Given this list of marker genes PGM2L1, SMC5, BBS12, TSR2, CHD5, CHST14, RPS28, LRP2, TP63, VPS13B, CLTC, NXN, MAPKAPK5, YWHAE, SALL4, TRPM3, TTC8 (tetratricopeptide repeat domain 8), BMP1, OCRL, WNT5A, ZBTB20, SCARF2, PGAP1, MGAT2, MYMX, EDEM3, EXTL3, TLK2 (NCBI Gene Id 11011), DHCR24, ADNP, DCHS1, KIF15 (kinesin family member 15), COPB2 (NCBI Gene Id 9276), MYMK, KRAS, TBR1, DBR1, SMARCA2, DVL3, TENM3, LRP4, PEX1, HHAT, DDR2, AGO1, COL11A2, BCORL1, CTBP1, CHRNG, PCDHGC4, NOTCH2, FANCF, SCN4A, C12orf57, PTEN, TBC1D2B, SNORD115-1, BCOR, AUTS2, ASPM, FANCG, BRCA1, DLG3, ZMYND11, BCL11B, SPECC1L, HS6ST2, CEP135 (centrosomal protein 135), KDM5A, AP3B2, ATP6V0A2, CLIP2, MKS1, SATB1, NTRK2, PEX13, EFEMP1, SCN1A, MCPH1, NSD1, CEP19, MAP2K2, TRIP12, PTCH1, OFD1, NBN, ASXL1, CHN1, RDH11, FOXP2, WDR35, LMNB1, UQCC2, INTS1, RBPJ, GPC6, RAI1, RAD51, KIF14, THOC6, KAT6B, SON, ACBD6, GPC3, PHOX2B, PDGFRB, SNAP29, KNL1, ITPR1, GPC4, KMT2A, RAB18, DMXL2, GATA4, PIGL, CRKL, PIGN, BBS7, POLR1C, PPP1R15B, MTOR, HSPG2, MSL3, BICRA, KAT5, KDM4B, RTL1, MASP1, POLR3A, TRIM32, MED12L (NCBI Gene Id 57726), PTPN11, SYNJ1, TBL2, DYNC1I2, SNX14, CERT1, COMT, NSD2, LMX1B, PWRN1, EED, NPHP1, KAT8, TUBGCP2, ZIC2, FBXO28, TMEM147, AFF3, HRAS, CHST3, MED12, FOXG1, GABRA3, RAPSN, UGDH, EZH2, WDR62, CASK, PIGT, ATP6V1B2, PIGW, ERMARD, PIGY, SEMA5A, PGAP2, FANCD2, FIBP, GABBR2, CEP295, ZNF292, CWC27, KCNB1, BUB1B, MYOD1, ATP1A2, RNU4-2, PRPS1, KCNC2, KREMEN1, FANCA, GNPNAT1, DGCR6, KCTD1, TBL1XR1, HNRNPR, SPOP, GABRG2, FBXO31, MEGF8, MVK (mevalonate kinase), PEX26, PITX1, CENPE, CDK19, SCLT1, CUX1, ORC1, EIF4H (eukaryotic translation initiation factor 4H), CLTCL1, BUD23, CHD1, WBP4, CAMTA1, ZMYM2, TAF1, KCNJ2, RNF2, HUWE1, CASP2, SMPD4, MOGS, SPEN, LIMK1, CRTAP, DPYSL5, NFIB, BRD4, FBN1, XRCC2, PRDM13, NAA60, H4C9, SLC19A3, KMT2C, RIT1, CEP57, HNRNPC, TRAK1, NR2F1, CCDC32, WASF1 (NCBI Gene Id 8936), SLC38A3, BBS5, CEP63, BCR, CIT, IRX5, UBE2T, STIL, KDM6A, LIG4, SLX4, DNA2, BAZ1B, TRRAP (transformation/transcription domain associated protein, NCBI Gene Id 8295), TBCK, SMO, ZSWIM6, GABRA5, MECP2, RNF135, BLTP1, SLC9A7, FOXP1, PUM1, TNRC6B, ESCO2, AMPD2, CHAMP1, SPIN4, PRR12, EXOC2, NUAK2, FBXL4, DNM1, TCOF1, CNOT2, PCGF2, ANKRD17, TWIST1, CUL4B, YY1, IL6ST, DONSON, LMNA, COL5A1, PIEZO2, PRMT7, RFC2, GMNN, UBR1, ACSL4, MAGEL2, MFSD2A, AP4E1, DYRK1A, TBCD, SPART, AP1S1, DVL1, CBL, ROR2, LTBP1, RECQL4, PGAP3, MUSK, PEX7, FGF12, TWIST2, SMC1A, NOTCH3, LDHD, QRICH1, RRAS, SETD2, CDH11, B3GAT3, NDN, CELF2 (CUGBP Elav-like family member 2), OTUD5, SASS6, MAP2K1, KDM1A, MTSS2, BRPF1, SIM1, DGCR2, ALDH6A1, DHODH, WDR26, SETD1B, DACT1, NFIA, ATP1A3, PIGA (NCBI Gene Id 5277), ARID1B (NCBI Gene Id 645070), MN1, NUP85, CACNA1A, COG1, DHX30, PAFAH1B1, CHD8 (chromodomain helicase DNA binding protein 8), FGFR2, RREB1, KIF11, NUS1 (NCBI Gene Id 116150), HERC1, EIF5A (eukaryotic translation initiation factor 5A), RBMX, GLE1, ARID2, TBX6, CD96, ATP7A, NALCN, PPP1R21, RBBP8, SLC26A2, TRMT10A, TMEM270, SLC1A2, OCA2, SLC39A13, PWAR1, ZFX, GP1BB, TRAPPC14, EBP, ASXL3, VAC14 (NCBI Gene Id 55697), LIFR, SPRED1, STAG2, DPH5, SKIC3, FHL1, UBE2A, MED13, GALNT2, CDK5RAP2, SHOC2, PYCR1, CNKSR2, RAF1, CTCF (CCCTC-binding factor), EFNB1, DEAF1, MYT1L (myelin transcription factor 1 like), KIF26A, KCNE5, NRAS, HIVEP2, PEX14, SUPT16H (NCBI Gene Id 6831), POLR1D, ANK1, RIN2, TFAP2B, DLK1, ANKLE2, POLR1A, PIGV, AGO2, PGM3, MCTP2, AMMECR1 (NCBI Gene Id 9949), HERC2, DALRD3, EXOSC2, SEPTIN9, TNNI2, HECTD4, APC2, MAPK1, CPLX1, ABCA5, RASA2, BBS4, EIF2AK3, RYR1, RBM10, PRKAR1B, FGF3, LZTR1, ERI1, BRIP1, BBS2, SKI, FKBP6, AFF4, ZMPSTE24, NCF1, KCNN3, AKT1, IDH1, DOCK3, DDB1, VPS35L, TOR1A, PPP3CA, TGFBR1, FAT4, LARP7, CDC42, BMPR1A, PIK3CA, FTSJ1, SEC24D, TGFB3, MAN1B1, FANCL, UBR7, H4C11, ELN, MAD2L2, SCN8A, FBXO11, TUBB, ORC6, SETBP1, SET (SET nuclear proto-oncogene), PEX12, FANCM, MAFB (MAF bZIP transcription factor B), ADAMTS2, FLCN, STAC3, GPKOW (G-patch domain and KOW motifs), CRELD1, PMM2, WDPCP, MAPK8IP3, NECTIN1, NONO, PEX19 (NCBI Gene Id 7835), RFX7 (NCBI Gene Id 64864), SYNGAP1, POGZ, HNRNPK, MAP3K7, IFT56, PDE4D, SEC24C, CNTNAP2, FIG4, GAD1, TCF4, BRAF (B-Raf proto-oncogene, serine/threonine kinase), CLP1, NAA20, RIPK4, FGD1, ADAMTS3, LETM1, SOS2, BPTF, SCNM1, TBX15, DLX4, TRAPPC10, SLC30A9, TAF13, HDAC4, SLC29A3, SUZ12, PEX6, KIF7, TUBB3, RTTN, HEATR3, PACS1, SATB2, MYCN, DNMT3A, ERCC6, SETD1A, GTF2IRD2, FZD2, BBS9, STEEP1, IGBP1, CYFIP2 (NCBI Gene Id 81032), SALL1, ZNF526, SNRPN, FLI1, TELO2, CLCN4, EHMT1, MKKS, TMEM107, SETD5, FANCE, BBS10 (Bardet-Biedl syndrome 10), ATAD3A, CNOT3, COLEC10, IFT172, ESS2, DRG1, IL1RAPL1, CDH2, EIF4A2, PARS2, PIK3R2, PSMD12, TRIP13, MEIS2, U2AF2, PLK4, VPS37D, CCDC47, AARS1, SH3PXD2B, ODC1, RRAS2, CLCN3, ALDH1A2, TRAF7, HBA1, SOS1, DHDDS, SZT2, PRRX1, CDK10, B3GLCT, ERCC4, ZEB2, DDX3X, FLII, ARHGEF2, TRIO, USP9X, COL3A1, SCAPER, SIAH1, COL9A3, NPAP1 (nuclear pore associated protein 1), MAPRE2, ACTB, RFWD3, FRA10AC1, C2CD3, PHC1, IFT57, UBE3B, GNB2, RNU4ATAC, INPPL1, UBE3A, PEX3, H4C3, ATRIP, KCNJ5, CHD7, ERCC1, MYL11, MAF, SLC25A24, IL11RA, ANKRD11, CSGALNACT1, ARVCF, FOXL2, BRCA2, DOK7, ESAM, LMBRD2, SNRPB, RERE, PIGO, CCDC115 (coiled-coil domain containing 115), UFD1, NELFA, COPB1, IFT140, NSRP1, PUF60, ASPH, PYCR2, IFT27, HNRNPU, ADAMTSL2, PEX5, HBA2, CAMK2G, GON7, PLOD1, CACNA1B (calcium voltage-gated channel subunit alpha1 B), NEUROG1 (neurogenin 1), TASP1, SLC45A1, DPF2, DGCR8, GSC, CHRNA7, KDM5C, APC, DPM1, CEP290, CCDC22, WARS1, COG8, CTU2, BUB1, SIN3A, BAP1, DDX59, ADAT3, TFE3, IFT74, ALX4, PPP2R5D, SOX6, EFEMP2, FZR1, NEK9, SOX11 (NCBI Gene Id 6664), MYH3, NAA10, RPS6KA3, KCNH1, POLR3GL, HCN1, MED13L, CCNK, IQSEC2, CTNND2, WAC, EP300, SMAD4, KATNB1, PEX10, SMAD2 (SMAD family member 2), PCLO, FREM1, ALG14, CKAP2L, SC5D, COLEC11, ATP6V1E1, UNC80, TAF4, JAG1, MID1 (NCBI Gene Id 8230), ARCN1, BUB3, ALG2, XRCC4, GRIN2D, RAD51C, UBAP2L (NCBI Gene Id 9898), STXBP1, IPO8, MRPS2, RAB11B, GABRA2, TGDS, METTL27, DNAJC21, DHCR7, MRAS, RAB3GAP2, AHDC1, AP3B1, SF3B2, MCM7, MKRN3, WWOX, LZTFL1, NECAP1, TRAIP, DYNC1H1, NEXMIF, METTL5, PRIM1, OSGEP, PURA, RAC1, SMOC1, CACNA1G, NARS1, IGF1R, ARL6, ZC4H2, SMS, MADD, GORAB, JMJD1C, PHF8, ABAT, KMT2E, NCAPD3, PEX11B, DPH2, KIFBP, GATAD2B, PPP1CB, CAMK2A, MEF2C, NRCAM, SLF2, CENPT, PLPBP, CEP55, FGFR1 (NCBI Gene Id 84151), NUP37, GABRB2, MEG3, ZNF148, YWHAG, PACS2, DSE, NOVA2, HNRNPH1, H3-3A, TSPEAR (NCBI Gene Id 54084), HS2ST1, SYT1 (NCBI Gene Id 6857), PPP2R1A, GTF2IRD1, FILIP1, PIGB, PEX2, CACNA2D1, ABL1, ZNF462, SLC6A17, ATR, DPH1, PPP1R12A, KMT2D, DYNC2LI1, SF3B4, UBA5, PKDCC, PIGG, NR4A2, DDX6, OTUD7A, HSD17B4, CDK13, NDUFS4, PEX16, SNORD116-1, FANCC, SPTBN1, HNRNPH2, STX1A, RHOA, NSDHL, NOG, SLC13A5, KANSL1, EEF1A2, GLI3 (NCBI Gene Id 2737), THUMPD1, TMCO1, BMP2, P4HB, RAD21, EFTUD2, PALB2, NF1, MINPP1, AFG2B, ZIC1, ZMIZ1 (NCBI Gene Id 57178), ACTG1, CFAP418, TBX1, DPYD, MLXIPL, PCNT, BBIP1, SPRED2, SCN3A, KPTN, WASHC5, PAK3, KLF13, RAP1B, GTF2I, BCL11A, OTUD6B, AGR2, COG7, KCNMA1, STRA6, COL11A1 (collagen type XI alpha 1 chain), BBS1, RPL10, ARX, SARS1, SLC32A1 (NCBI Gene Id 140679), B9D2, RPS19, NSUN2, BRF1, TRMT1, POLA1, TXNL4A, HIRA, STT3A, POLR1B, PHIP, PAX3, RRAGC, ATRX, DHX9, KCNA2, ACTL6B, DOCK6, ALDH1A3, KDM5B, GJA1, MPDZ, SOX5, SDCCAG8, DPP9, ATP6V1A, CDK6, SRCAP, FAM20C (FAM20C golgi associated secretory pathway kinase), FANCI, CREBBP, JARID2, MED25, GJA5, UMPS, TFAP2A, RLIM, CHD4, FGFR3, FANCB, CEP152, SOX9, H4C5, TGFB2, PHF6, NFIX, ZBTB18, HBB, EBF3, ADARB1, PUS7 (pseudouridine synthase 7), GJA8, CDC42BPB, BGN, SLC2A10, PQBP1, TMEM237, FLNA, DNAJC30, TOE1, here is a description of the gene set: Abnormality of the palpebral fissures studied in species Homo sapiens An anomaly of the space between the medial and lateral canthi of the two open eyelids. Human Gene Set: HP_ABNORMALITY_OF_THE_PALPEBRAL_FISSURES